The following is a description of a gene set: Human Gene Set: GOBP_CORNEA_DEVELOPMENT_IN_CAMERA_TYPE_EYE The progression of the cornea over time, from its formation to the mature structure. The cornea is the transparent structure that covers the anterior of the eye. studied in species Homo sapiens, and this is the list of marker genes: PRICKLE1, FOXE3, SOX11, WNT9B, WNT6, ADAMTS9, LIMK2, KERA, WNT2B, PAX6, WNT9A, KRT12, ANGPTL7